Given this list of marker genes CD34, MIR128-1, TSLP, LILRA2, ISL1 (NCBI Gene Id 3670), FOXP1, HAVCR2, here is a description of the gene set: The appearance of macrophage colony-stimulating factor due to biosynthesis or secretion following a cellular stimulus, resulting in an increase in its intracellular or extracellular levels. Human Gene Set: GOBP_MACROPHAGE_COLONY_STIMULATING_FACTOR_PRODUCTION studied in species Homo sapiens